Given this list of marker genes MASP1, COLEC11 (NCBI Gene Id 78989), FCN1, FGA, FCN2, FGG, MBL2, COLEC10, FCN3, FGB, here is a description of the gene set: Human Gene Set: KEGG_MEDICUS_REFERENCE_LECTIN_PATHWAY_OF_COAGULATION_CASCADE_FIBRINOGEN_TO_FIBRIN Lectin pathway of coagulation cascade, fibrinogen to fibrin. Pathway ID: N01502. Pathway type: Reference. Pathway class: nt06171 SARS coronavirus 2 (SARS-CoV-2). species: Homo sapiens Pathway Definition from KEGG: FG -- (F2a,((MBL2,COLEC10/11,FCN)+MASP1)) -> Fibrin